Given this list of marker genes CPT1B, CPT1C, CPT2, CROT, CPT1A, CRAT, here is a description of the gene set: studied in species Homo sapiens Human Gene Set: GOMF_CARNITINE_O_ACYLTRANSFERASE_ACTIVITY Catalysis of the transfer of an acyl group to an oxygen atom on the carnitine molecule.